The following is a description of a gene set: Mouse Gene Set: GOMF_PROTEIN_HETERODIMERIZATION_ACTIVITY Binding to a nonidentical protein to form a heterodimer. studied in species Mus musculus, and this is the list of marker genes: H2bc3, H2ac4, Lsm6, H3f3c, Macroh2a1, H2az1, Abtb2, H2bc12, Sim1, Chuk, Itgb1, Taf8, Nolc1, Ugt1a10, Taf9b, Pglyrp3, Hif1a, Sohlh2, Taf13, Ralgapa1, H2bc26, Atp1a1, H2bc21, Macroh2a2, Hnf1a, Kcnk1, Arnt2, Ralgapb, Mlxipl, Mttp (NCBI Gene Id 69796), Slc3a1, Tenm1, Il12b, Bmal1, Adcy8, Slc51b, Srgap2, Ikbkb, Kcnb2, Drap1, H2ac7, Supt5, Taf3, Ran, Psmf1, Ext2, Psg20, Katnb1, Gpha2, Rraga, Zhx1, Aoc3, Cenpt, Ikzf3, H2ac20, Bok, Il17f, Abcg8, Fcer1g, Taf1, Sohlh1, Uba2, Fxr2, Gadd45a, Tenm4, Gabbr2, Qtrt2, Slc3a2, Atp1b2, Adora1, Itga3, Sgtb, Taf11, Usf1, Nr4a1, P4hb, Tcf4, Nr4a2, Aurka, Smc3, Rragc, Miga2, Tenm2, Micu1, Taf9, Lsm5, H2ac24, Atf3, Pdgfa, Mapk4, Gabbr1, Ugt1a9, Ugt1a7c, Creb3l3, H2al2a, Mcl1, Mlx, H2ac21, Prmt5, H2az2, Npas1, Pdgfb, Syt10, Pafah1b1, H2bc1, Jam3, Adra1b, Hip1r, Sri, Tcf12, Tenm3, Nfe2l1, Cd247, App, Pef1, Supt4a, Bdkrb2, Bud23, Dgkd, Ywhah, H2ac13, Pik3r1, Pdss1, Trmt112, Bcl2, Abcd2 (ATP-binding cassette, sub-family D member 2), Il12a, Tubb2b, Bmp6, Katna1, Adra2a (adrenergic receptor, alpha 2a), Abcg1, Tlr6, Cebpb (NCBI Gene Id 18031), H2bc14, Fbxo7, Tcf3, Tlr4, Tfe3, Snx2, Ahr, H2ac23, Fmr1, Pafah1b3, Mef2d, Xbp1, H2ac11, Agtr1b, Gtf2a2, Chrac1, H2ac25, Arnt, Syt6, Ppp2ca, Taf7, Zbtb1, Ticam2, Adra2c, Pglyrp4, Atf4, H2bc9, Ugt1a6a, P2ry1, Atf6, Miga1, Slc51a (NCBI Gene Id 224113), H2bc27, Erbb2, Pml, Fzd4, Kcnk2, Ugt1a6b, Nfyc, Top2a, Syt5, Zfp318, Tpm2, Pdcd6 (programmed cell death 6), Ugt1a5, Il17a, Kcnk3, Npas3, Usf2, H2ac12, Fzd2, Atp1a2, Ralgapa2, Micu3, Rragd, Fxr1 (NCBI Gene Id 99741), Epas1, H2ac15, Sae1 (SUMO1 activating enzyme subunit 1), Tpm4, Irak1, Fzd9, H2aj, Adra1a, Neurod1, Sdcbp, Smc1a, Cyba, Kcnb1, Bak1, Nfyb, Add2 (adducin 2), Phb1, Ceacam2, Zfp397, H2ac6, Hes6, H2bl1, Ugt1a1, H2ac10, Ropn1, Sephs1, Pafah1b2, Gphb5, H2bc18, Vapb, Zhx3, Nae1 (NEDD8 activating enzyme E1 subunit 1), Kcnk13, Pole3, Gtf2a1 (general transcription factor II A, 1), Slc7a13, Zhx2, Hexa (hexosaminidase A), H2ap, Erbb3, Bhlha9, Pik3r2, Cenpw, Bcl10, Sdcbp2, Mef2c, Taf4b, H2ac22, Bhlhe40, Syt1, Sgta, Krt10, Bax, Supt4b, Trp53, H2bc22, Sos2, Tpm1, Pole4, Irak2, Mapk6, Abcd1, Ddit3, Taf12, Agtr1a, Slc7a8, Tfeb, Syt3, Taf6, Kcnk9, Tuba1a, Hip1, Bard1, Fzd1, Bhlhe41, Cybb, Abtb3, Sos1, Uba3, Lsm7, H2ax, Abcg5, H2ac8, Phb2, Abcg4, Irak3, Npas4, Gca (grancalcin), Cenpa, Sim2, Birc5, Cav1, Mettl3, Micu2, Neurod2, Tfap2b, Slc7a9, Bcl11a, Ywhae, Ikbkg, Syt4, Runx1, Krt25 (keratin 25), Ugt1a2, Rcc1, Dr1, Tcof1, Snx1, Apoa2, Krt1, Qtrt1 (NCBI Gene Id 70199), Mef2a, Pdss2 (prenyl (solanesyl) diphosphate synthase, subunit 2), Atf2 (NCBI Gene Id 97033), Add1, Jdp2, Ugt1a8, Cenps, Supt7l, Ext1, Cav2, Ppp2r1a, Ceacam1, Vapa, Taf6l, Hsf1, Adrb1 (adrenergic receptor, beta 1), Cebpa, Atp1b1